The following is a description of a gene set: species: Mus musculus Mouse Gene Set: GOBP_PYRIDINE_NUCLEOTIDE_BIOSYNTHETIC_PROCESS The chemical reactions and pathways resulting in the formation of a pyridine nucleotide, a nucleotide characterized by a pyridine derivative as a nitrogen base., and this is the list of marker genes: Aspdh, Slc25a51, Nmnat1, Nadk2, Nmnat3, Afmid, Nadk, Ido1, Haao, Ido2, Qprt, Kynu, Naprt, Idh2, Nmrk2, G6pdx, Nampt, Kmo, Nadsyn1, Nmnat2, Nmrk1